Given this list of marker genes Psmd12, Adrm1, Psmd8, Adrm1b, Psmd3, Sem1, Psmd13, Psmd14, Psmd11, here is a description of the gene set: Mouse Gene Set: GOCC_PROTEASOME_REGULATORY_PARTICLE_LID_SUBCOMPLEX The subcomplex of the proteasome regulatory particle that forms the peripheral lid, which is added on top of the base subcomplex. studied in species Mus musculus